The following is a description of a gene set: Abnormal circulating porphyrin concentration An abnormality in the synthesis or catabolism of heme. Heme is composed of ferrous iron and protoporphyrin IX and is an essential molecule as the prosthetic group of hemeproteins such as hemoglobin, myoglobin, mitochondrial and microsomal cytochromes. Human Gene Set: HP_ABNORMAL_CIRCULATING_PORPHYRIN_CONCENTRATION species: Homo sapiens, and this is the list of marker genes: ERCC8 (NCBI Gene Id 2075), FECH, GATA1, CPOX, ABCB7, ALAD, PPOX, UROD, CLPX, UROS, ALAS2